Given this list of marker genes Eif6, Mtres1, Mrrf, Ndufab1-ps, Cpeb2, Nmd3, Malsu1 (mitochondrial assembly of ribosomal large subunit 1), Nemf, Ndufab1, Npm1, Ola1, Eif1a, Cpsf6, Dhx33, Rbm3, Mtrfr, Ltn1, here is a description of the gene set: Mouse Gene Set: GOMF_RIBOSOMAL_LARGE_SUBUNIT_BINDING Binding to a large ribosomal subunit. studied in species Mus musculus